Given this list of marker genes Abl2, Ywhab, Stk38, Zfp967, Hspa2, Gpt2, Tmem167, Nfxl1, Rspo2, Entr1 (endosome associated trafficking regulator 1), Grip1, AI182371, Mapk10, Mbnl3 (muscleblind like splicing factor 3), Rnf145, Arid4a (AT-rich interaction domain 4A), Pip4p2, Sema6d, Angpt2, Ubb, Ak4, Ube2e1, Zfp970, Atad2b, Cuzd1, Tomm5 (translocase of outer mitochondrial membrane 5), Tnrc6b (trinucleotide repeat containing 6b), Mpped2, Camta1, Bmp2k, Parn, Pde5a, C1qtnf7, Tmem64, Gad1, Dmd, St8sia4, Rab23, Ammecr1, Stc1, Golm2, Tmpo, Onecut2, Lrrc38, Ets1, Ranbp10, Lgmn, Naxd (NAD(P)HX dehydratase), Api5, Prdm14, Rnase2a (NCBI Gene Id 93726), Necab1, Ppfia2, Jazf1, Sh3kbp1, Txndc15, Nr2e1, Decr2, Plekhh1, Rfx3, Ormdl1, Ttc6, Tcstv4, Zfp940, Pten, Dpp4, Fgl2, Tet2, Cdk6, Leprotl1 (NCBI Gene Id 68855), Sdc3, Cpeb2, Gm14322, Cdhr3, Nox4, Dnah2, Slc6a7, Tab3, Zfp40, A830018L16Rik, Hrk, Ncoa4, Tiam1, Aqp9, Cbln4, Rnf169, Mfsd6, Gpr65, Lrp6, Naa16, Ubl4a, Dnm1l, Rdx, Dip2b, Fryl, Dmrta2, Pigyl, Dlg2, Tpd52l2, Pdss2, Ush2a, here is a description of the gene set: from publication Chen Y, Wang X (PMID 31504780) species: Mus musculus Mouse Gene Set: MIR_6999_3P Genes predicted to be targets of miRBase v22 microRNA mmu_miR_6999_3p in miRDB v6.0 with MirTarget v4 prediction scores > 80 (high confidence targets).